Given this list of marker genes Grm4, Snap25, Atp2b4, Grm8, Rims1, Tenm3, Stx1a, Grin2b, Canx (calnexin), Stx1b (NCBI Gene Id 79361), Apba1, Cacna2d1, Vdac1, Grin3b (NCBI Gene Id 170483), Celsr3, Napa (N-ethylmaleimide sensitive fusion protein attachment protein alpha), Scn8a, Stx2, P2ry4, Kctd8, Cdh10, Nectin1, Gria3, Kctd12b, Itga3, Ntng2, Grin2d, Cacna1d, Nrxn3, Cacna1a, P2rx1, P2rx2, Gabra2, Nrxn1, Gabrb1, Cplx3 (complexin 3), Ryk, Hcn1, Ntng1, Gabrb2, Gpm6a, Nptn, Gria2, Otof, Syt11, Atp2b2, Cacna2d2, Snap91, Phb1, Grm7, Napb (N-ethylmaleimide sensitive fusion protein attachment protein beta), Kcnma1, P2ry2, Cacna1h, Grin1, Cdh2, Lpar2, Nrg1, Stx19, Stx11, Cacna2d3, P2ry1, Afdn, Cntnap2, Lrfn3, Flot2, Gria1, Dgki, Adra2a, Kctd12, Fzd3, Gria4, Atp2b1, Kcnj8, Gabra3, here is a description of the gene set: Mouse Gene Set: GOCC_PRESYNAPTIC_ACTIVE_ZONE_MEMBRANE species: Mus musculus The membrane portion of the presynaptic active zone; it is the site where docking and fusion of synaptic vesicles occurs for the release of neurotransmitters.